The following is a description of a gene set: Microangiopathic hemolytic anemia species: Homo sapiens Human Gene Set: HP_MICROANGIOPATHIC_HEMOLYTIC_ANEMIA, and this is the list of marker genes: CFB, THBD (thrombomodulin), CFHR3, C3, STAT4, SAT1, CFHR1, CFI (NCBI Gene Id 3426), IRAK1, ADAMTS13, HELLPAR, CD46, SPP1, CFH